Given this list of marker genes TM4SF1 (NCBI Gene Id 9004), JAM2, PFKFB2, CRYM, RRAD, CLCN3, GJA1, NKX2-5, PTGER4, KCNJ8, LEPROTL1, PLAU (plasminogen activator, urokinase), F5, SLC5A3, CTSB, MARCKS (NCBI Gene Id 4082), C6, G0S2, NRP1, CXCL12, HBB, PDE4B, CCL2, TGFBI, IDH1, PPP1R3C, ZDHHC11, CCL21 (NCBI Gene Id 6366), B3GALNT1, IFIT1, CD14, S100A8, PDE4D (NCBI Gene Id 654081), HEY2 (hes related family bHLH transcription factor with YRPW motif 2), TNFSF10, GPR22, PTGIS, B3GALT2, ATP1A3, APLNR, CACNB2, GIMAP4, here is a description of the gene set: Chronic unloading of the failing heart with a left ventricular assist device (LVAD) can decrease cardiac mass and myocyte size and has the potential to improve contractile function. To study the effect of chronic ventricular unloading on myocardial gene expression, a microarray (U133A, Affymetrix) profiling gene expression was compared before and after LVAD support in seven patients with idiopathic dilated cardiomyopathy and end-stage heart failure. On average, 1,374 +/- genes were reported as increased and 1,629 +/- 45 as decreased after LVAD support. A total of 130 gene transcripts achieved the strict criteria for upregulation and 49 gene transcripts for downregulation after LVAD support. Upregulated genes included a large proportion of transcription factors, genes related to cell growth/apoptosis/DNA repair, cell structure proteins, metabolism, and cell signaling/communication. LVAD support resulted in downregulation of genes for a group of cytokines. To validate the array data, 10 altered genes were confirmed by real-time RT-PCR. Further study showed that the phosphoinositide-3-kinase-forkhead protein pathway and proteins related to nitric oxide synthesis, including eNOS and dimethylarginine dimethylaminohydrolase isoform 1 (DDAH1, an enzyme regulating endogenous nitric oxide synthase activity), were significantly increased during the cardiac remodeling process. Increased eNOS and DDAH1 expression after LVAD support may contribute to improved endothelial function of the failing hearts. Human Gene Set: CHEN_LVAD_SUPPORT_OF_FAILING_HEART_DN from publication Chen Y, Park S, Li Y, Missov E, Hou M, Han X, Hall JL, Miller LW, Bache RJ (PMID 12824457) Down-regulated genesin the left ventricle myocardium of patients with heart failure following implantation of LVAD (left ventricular assist device). species: Homo sapiens